The following is a description of a gene set: Mouse Gene Set: REACTOME_ANTIGEN_PROCESSING_UB_ATP_INDEPENDENT_PROTEASOMAL_DEGRADATION Antigen processing: Ub, ATP-independent proteasomal degradation species: Mus musculus, and this is the list of marker genes: Psmb3, Psma5, Psma6, Psmb7, Psme2b, Psmb1, Psma7, Psmb10, Psma4, Psma1, Psma2, Psmb8, Psma3, Psme2, Psmb2, Psmb6, Psmb5, Psme1, Psmb4